Given this list of marker genes S100b, Lbp, Tab2, Hmgb1, Tifa, Tlr4, Dusp6 (NCBI Gene Id 67603), Ikbkb, Casp8, Sftpd, Map2k4, Nfkbia, Cd14, Nfkb2, Ager, Dusp7, Map2k3, Nfkbib, Nkiras1, Ube2d1 (NCBI Gene Id 216080), Lrrc14, Peli2, Tirap, Itgb2, Jun, Mapk3, Fadd, Ube2v1, Map2k7, Nfkb1, Traf3, Irf7, Mapk8, Ppp2r5d, Nlrc5, Mapk7, Irf3, Mapk9, Ppp2r1b, Optn, Ube2n, Map2k6, Nlrx1 (NLR family member X1), Vrk3, Tab1, Map3k8, Tab3, Ecsit, Mapk11, Ly96, Bpi, Fos, Dnm2, Ubb, Irak1, Birc3, Ly86, Ticam2, Rela, Rps6ka5, Cul1, Rps27a (NCBI Gene Id 78294), Plcg2, Mapk14, here is a description of the gene set: species: Mus musculus Reactome Pathway: Toll Like Receptor 4 (TLR4) Cascade electronically inferred by orthology from the curated human pathway part of: Toll-like Receptor Cascades This event has been computationally inferred from an event that has been demonstrated in another species.<p>The inference is based on the homology mapping from PANTHER. Briefly, reactions for which all involved PhysicalEntities (in input, output and catalyst) have a mapped orthologue/paralogue (for complexes at least 75% of components must have a mapping) are inferred to the other species.